Given this list of marker genes ELOVL5, PRKAG1, TXLNGY, IL2, DMRTB1, CCDC126, NNAT, RASGRP2, HNRNPA2B1, GIMAP4, IZUMO1, NFATC4, UBE2E2, PTPRA, CDK5R1, GPRASP2, LRRC8B, ACOT7, ATXN1, JUN, SMAD1, DYNC1I2, ZNF777, ONECUT2, DERL1, IGFBP5, GPBP1, ARL6IP6 (ADP ribosylation factor like GTPase 6 interacting protein 6), AAMP, CMTM4, HSPA1L, NOL4, ATP6V1A, PCDH10, CNTF, GREB1, ZC3H11A, DAZL, CYLD, NAA50, SPTB, SIX4, SREBF2, FLNC, CBFA2T3, COL13A1, GIPC2, WRN, EFNB3, CASQ2, FHL1, BCAP31 (B cell receptor associated protein 31), HSPA1B, GABRB1, MOBP, SSBP3 (NCBI Gene Id 55126), CISH, EEFSEC, GRIK1, MMP19, HS6ST3, NR2C2, NR4A3, POU4F3, HSPB2, EVA1C, TRDN, NR2F1, ST13 (ST13 Hsp70 interacting protein), SPO11, EWSR1, JARID2, DND1, MIR137HG, SEM1, ME1, TSSK3, HSPH1, PDLIM5, MAPK1IP1L, NUFIP2, GRM1, KCNQ1, BPIFB1, NKX2-1, CREM, SETD2, HSPD1, NFKBID, NFAM1, LINC00114, STC1 (NCBI Gene Id 82914), HERC4, DUSP1, PPID (NCBI Gene Id 5481), TRIB1, PDE6D, MORF4L2, RALGDS, EGF, COL16A1, TRIM8, HIVEP2, KNTC1, FGF5, ENPP2, RIMS2, ACTN2, PPT2, FANCL, C12orf50, HIPK1 (homeodomain interacting protein kinase 1), SHANK1, KRT85, EIF4G2, NEK6, ASCL4, PCDH7, DDX17, CRISP1, IRF2BPL, TSPAN31, ZNF212, TFAP2D, RBPMS, SERPINH1, MBNL2, FOXR1, PEX11B, TMEM243 (transmembrane protein 243), NT5C3A, VASH1, ARL4C, UMODL1, SGF29, TREX2, PNKD, YWHAG, CAMKV, SHC3, SPIN1, GIGYF1, ADAMTS2, OTX2, FSTL3, PLEC, MED12, MBD6, KRTAP19-6, OTX1, RFX4, ZBTB20, RNF144B, TPI1P2, CLASRP, ELAVL4, HOXB8, LMOD1, RGS8, TRERF1, FKBP4, HSPB8, STAG2, DAZ2, ABHD3, PIP5K1A, SRSF1, BCL9, EIF5, PNMA1, CHORDC1, IL1RAPL1, EGR3 (NCBI Gene Id 1960), GOT1L1, LINC01106, ALKBH6, MAP2, HSPA8, BNC2, KRIT1, CHST2, TPM2, CCT4, RAB30, CRYAB, XPNPEP3, KCNK9, IER5L, RALYL, PIP5K1P1, TSACC, TSPAN6 (NCBI Gene Id 7105), LARP4, PLA2G4D, PDGFB, CLDN2, C1QTNF7, CLEC4D, FLT4, SRP54, BCL6, TMEM71, POLD4, FNDC9, HIKESHI, FOS, RHBDD3, CSRNP3, GNRHR2, TAB2, MAPK14, TOMM40L, CACNA1D, TBX5, CACNA2D2, PACSIN3, RPH3AL, NFATC3, E2F3, OTP, TYR, SLC25A41, FSCB, LAMTOR3, SLC5A7, ABCC5, STIM2, EIF4A2, TGIF1, FBXW4, DNAJB1, MEF2C, GAD1, MID1, CCT8, RAB6B, MAT2A, BICRA, OPRD1, KDM3A, DMRT1, GDPD3, MARCHF10, TJAP1, PLOD1, LHFPL2, CCT3, PTGES3 (NCBI Gene Id 10728), MYOCD, SMYD1, HTN1 (histatin 1), HLA-B (NCBI Gene Id 730410), HS3ST4, DMD, DNAJB5, LAP3 (leucine aminopeptidase 3), MARCHF1, ITGA8, HSPA1A, here is a description of the gene set: Human Gene Set: HSF2_01 Genes having at least one occurrence of the motif NGAANNWTCK in the regions spanning 4 kb centered on their transcription starting sites. This matches the HSF2 transcription factor binding site V$HSF2_01 (v7.4 TRANSFAC). studied in species Homo sapiens